Given this list of marker genes TMPRSS6, CTSK, ADAMTS15, MIR98, LRP1, NOXO1, PBXIP1, PRSS2, TGFB2, TGFB1, KLK5, KLK4, MIR92A1, DDR1, TIMP3, MMP1, MMP8, MMP19, KIF9, CLASP1, CLASP2, TPSAB1, CST3 (cystatin C), FLOT1, CMA1, STAT3, MMP7, KLK7, MMP3, MMP9, ELANE, ADAMTS4, SH3PXD2B, MIR24-1, MMP2, MMP14, ADAMTS5, PDPN, FAP, IL6, MMP13, CTSS, RECK, CAPG, GSN, ADAM10, CTSV, WASHC1, ADAM15, PRSS1 (serine protease 1), MMP11, HPN, LCP1, MMP12, MIR29B1, MIR29C, MMP20, FGFR4, CTSG, CARMIL2, DPP4, MELTF, MMP10, ENG, ADAM8, EXOC8, MIR205, PLG, DDR2, FURIN, MMP15, MIR195, LAMC1, FSCN1, here is a description of the gene set: studied in species Homo sapiens Human Gene Set: GOBP_EXTRACELLULAR_MATRIX_DISASSEMBLY A process that results in the breakdown of the extracellular matrix.